The following is a description of a gene set: Genes negatively differentially expressed in cell type: CD8+ T cell upon treatment with cytokine: C5a in mouse lymph nodes in vivo. from publication Cui A, Huang T, Li S, Ma A, Pérez JL, Sander C, Keskin DB, Wu CJ, Fraenkel E, Hacohen N (PMID 38057668) studied in species Mus musculus Mouse Gene Set: CUI_T_CELL_CD8_C5A_RESPONSE_DN Cytokines mediate cell-cell communication in the immune system and represent important therapeutic targets. A myriad of studies have highlighted their central role in immune function, yet we lack a global view of the cellular responses of each immune cell type to each cytokine. To address this gap, the authors created the Immune Dictionary, a compendium of single-cell transcriptomic profiles of more than 17 immune cell types in response to each of 86 cytokines (>1,400 cytokine-cell type combinations) in mouse lymph nodes in vivo. A cytokine-centric view of the dictionary revealed that most cytokines induce highly cell-type-specific responses. For example, the inflammatory cytokine interleukin-1β induces distinct gene programmes in almost every cell type. A cell-type-centric view of the dictionary identified more than 66 cytokine-driven cellular polarization states across immune cell types, including previously uncharacterized states such as an interleukin-18-induced polyfunctional natural killer cell state., and this is the list of marker genes: Fos, Hspa1a, Hspa1b, Junb, Klf2, Jun, Klf6